The following is a description of a gene set: This study aimed to identify gene expression markers shared between both influenza hemagglutination inhibition (HAI) and virus-neutralization antibody (VNA) responses. We enrolled 158 older subjects who received the 2010-2011 trivalent inactivated influenza vaccine. Influenza-specific HAI and VNA titers and mRNA-sequencing were performed using blood samples obtained at Days 0, 3 and 28 post vaccination. For antibody response at Day 28 versus Day 0, several gene sets were identified as significant in predictive models for HAI (n=7) and VNA (n=35) responses. Five gene sets (comprising the genes MAZ, TTF, GSTM, RABGGTA, SMS, CA, IFNG and DOPEY) were in common for both HAI and VNA. For response at Day 28 versus Day 3, many gene sets were identified in predictive models for HAI (n=13) and VNA (n=41). Ten gene sets (comprising biologically related genes, such as MAN1B1, POLL, CEBPG, FOXP3, IL12A, TLR3, TLR7 and others) were shared between HAI and VNA. These identified gene sets demonstrated a high degree of network interactions and likelihood for functional relationships. Influenza-specific HAI and VNA responses demonstrated a remarkable degree of similarity. Although unique gene set signatures were identified for each humoral outcome, several gene sets were determined to be in common with both HAI and VNA response to influenza vaccine. species: Homo sapiens from publication Ovsyannikova IG, Salk HM, Kennedy RB, Haralambieva IH, Zimmermann MT, Grill DE, Oberg AL, Poland GA (PMID 27534615) Human Gene Set: OVSYANNIKOVA_PBMC_FLUARIX_AGE_50_74YO_COMMON_WITH_BOTH_HAI_AND_VNA_28DY_VS_3DY_USED_IN_HAI_AND_VNA_RESPONSE_MODELS_UP Genes up-regulated in peripheral blood mononuclear cell 28d vs 3d in adults (50-74) (in common with both HAI and VNA) after exposure to Fluarix, time point 28D, administered i.m.. Comment: Common Genesets with genes entering regression models for HAI and VNA Responses, withlog2 Day 28 vs Day 3 fold-change in gene expression as the explanatory variables, and this is the list of marker genes: EBI3, FH, ACSL4, SUCLA2, FYN, HSD17B12, S100B, ACSL1, TLR3, TUBG1, TLR7, LIG3, TLR9, SMUG1, ACSL5, SLC25A1, GALR2, SDHA, OGDH, INHBA, FASN, IDH2, ACO2, NF1, VLDLR